The following is a description of a gene set: species: Homo sapiens Human Gene Set: HP_PITUITARY_CORTICOTROPIC_CELL_ADENOMA Pituitary corticotropic cell adenoma A type of pituitary adenoma that produces adrenocorticotropic hormone (ACTH)., and this is the list of marker genes: BRAF, CDKN2C, USP48, ATRX, MEN1, CDKN2B, CDKN1B, NR3C1, TP53, GNAS, USP8 (ubiquitin specific peptidase 8), CDH23 (cadherin related 23), CDKN1A